Given this list of marker genes Oxtr, Avpr2, Avpr1a, Avpr1b, Drd5, here is a description of the gene set: Mouse Gene Set: GOBP_REGULATION_OF_SYSTEMIC_ARTERIAL_BLOOD_PRESSURE_BY_VASOPRESSIN studied in species Mus musculus The regulation of blood pressure mediated by the signaling molecule vasopressin. Vasopressin is produced in the hypothalamus, and affects vasoconstriction, and renal water transport.